Given this list of marker genes Relch, Sntg1 (NCBI Gene Id 71096), Sema6d, Cbx8, Mllt10, Cul1, Mbd5, Gria2, Eif4b, Prpf39, Rap2c, Stk24, Pde1c, Ski, Elmod2, Far1, Pthlh, Hectd2, Meioc, Tshz1, Zic1, Frmd4a, Wdr44, Efr3a, Taf4, Cdca4 (cell division cycle associated 4, NCBI Gene Id 71963), Gabrg2, Ube2g1, Nectin4, Muc15, Dld, Chodl, Vezf1, Abhd13, Pcm1, Esyt2, Arhgef6 (Rac/Cdc42 guanine nucleotide exchange factor 6), Hace1, Alyref, Tenm3, Azin1, Mpp7, Map4k3, Chd7, Trhde, Cdk7, Dyrk1a, Mtmr6, Suz12, Eef1e1, Brcc3, Kcng1, Dcun1d4, Traf6, Gpr22, Tbcel, Fmr1, Dnaja3, Map1b, Dipk1b, Lrch3, Rwdd2b, Lrrc4c, Gspt2, Wsb1, Syde2, Nptn, Cnot2, Nin, Lrrk2, Galnt13, Pafah1b1, Dach2, Taf3, Or5b95, Ppfibp1, Tm9sf3, Bdp1, Dnajb14, Slc40a1, Ldb2, Flvcr1, Tmem237, Yaf2, Ankra2, Dclk1, Casp8ap2, Gabra1, Tmem33, Cldn10 (claudin 10), Gpsm2, B4galt6, Ube2v2, Sub1, Serpind1, Zfp719, Crppa, Chst2, Stoml2, Slx4ip, Tsc22d2, Rab22a, Rev1, Umodl1, Ythdf3, Dlgap1, Syne2 (NCBI Gene Id 630548), Sqle, Edil3, Wasl, Scn2a, Cops4 (NCBI Gene Id 52442), Trak2, Champ1, Fbn1, Ric1, Tfr2, Tns3, Lemd3, Rnf19a, Lrig1, Col3a1, Slc5a12 (NCBI Gene Id 98907), Cdkn2c, Bclaf3, Scn3a, Skp1, Asxl2, Zfp644, Zfp608, Usp42, Nbea, Dmxl2, Nufip2, Cdk1, Mef2c, Arfip1, 1110004F10Rik, Golph3, Scn9a, Hexb, Pax3, Zfp951, Nampt, Ndnf, Sumf1, Crls1, Il22ra2, Ythdc2, Ncoa7, Senp5, Zdbf2, Larp4b, Sema3d (NCBI Gene Id 74345), Hoxd1, Fam135a, Bod1l, Cpeb4, Lhfpl3, Zfp708, Spred1, Fst, Xkr4, Cpvl, Neurod1, Oaz2, Mapk4 (mitogen-activated protein kinase 4), Gpr82, Fbxl22, Arf1, Tia1, Ccny, Apbb2, Col23a1 (collagen, type XXIII, alpha 1), Etl4, Gpr158, Glce, Zswim6, Deaf1, Cep170, Commd8, Myc, Rap1gap2, Caap1, Adnp2, Omg (NCBI Gene Id 18377), Ap4e1, Camta1, Prl2c2, Ptprb, Caprin1, Tpp2, Nkrf, Spryd4, Mfsd3, Ubr1, Cpt1a, Pclaf, Kctd12, Psmg2, Tead1, Naaladl2, Slc4a5, Prdm16, Ccdc88a, Kif2a, Zmym2, Tmem183a, Zdhhc17, Lrp3, Kcns3, Rora, Alyref2, Sacm1l, Gtf2a1, Klhl14, Edem3, Zfp712, Dkk1, Oog3, Mafb, Setd2, Stim2, Eea1, Chd1, Pcsk2, Ccng2, Srsf1, Zfp420, Zfp462, Tbk1, Slitrk6, Ubl3, Dr1, Pappa2, Fubp1, Ankib1, Pds5b, Lrrtm2, Sdcbp, Pum1, Ate1, Tmod2, Dock3, Zfand5, Atad5, B3galt2, Fcho2, Foxj1, Wtap, Ppm1b (NCBI Gene Id 19043), Prl2c3, Bdnf, AA467197, Angpt1, Figla, Sptan1, Slc17a6 (NCBI Gene Id 73055), Htr2c, Tmf1, Gja1, Mplkip, Hspe1, Ints2, Cert1, Ube2e1, Mdp1, Brd2, Supt7l, Trappc11, Mospd2, Tmed5, Fam133b, Kcnh8, Ing4, Abca15, Sbspon, Itm2b (NCBI Gene Id 214227), Elf1, Pag1, Ttc39b, Slc30a4, Prkg1, Slf1, Pik3c2g, Cdcp1 (CUB domain containing protein 1), Npat, Reps2, Setd1b, Tmem245, H2bc4, Pard6g, Gabrq, Tmem47, Egln1, B3galt1, Fut9, Trpc1, Emp1, Tmem65, Slc2a13, Tbc1d12, Samd13, Kmt2c, Rims2, Usp15, Inpp4a, Usp34, Khdrbs1, here is a description of the gene set: from publication Chen Y, Wang X (PMID 31504780) species: Mus musculus Genes predicted to be targets of miRBase v22 microRNA mmu_miR_5098 in miRDB v6.0 with MirTarget v4 prediction scores > 80 (high confidence targets). Mouse Gene Set: MIR_5098